The following is a description of a gene set: Human Gene Set: WP_OCTADECANOID_FORMATION_FROM_LINOLEIC_ACID Octadecanoid formation from linoleic acid studied in species Homo sapiens, and this is the list of marker genes: CYP3A4, CYP1A2, ALOX12B, ALOX15, GPX4, CYP2C19, EPHX3, ALOXE3, PTGS1, CYP2C8 (NCBI Gene Id 1558), CYP4A11, PTGS2, CYP2C9